The following is a description of a gene set: Human Gene Set: GOBP_REGULATION_OF_ENDOPLASMIC_RETICULUM_UNFOLDED_PROTEIN_RESPONSE studied in species Homo sapiens Any process that modulates the frequency, rate or extent of endoplasmic reticulum unfolded protein response., and this is the list of marker genes: PPP1R15B, XBP1, AKT2, COPS5, BAK1, DAB2IP, ATAD3A, AKT1, AGR2, DDRGK1, FICD, ATF6B, ATF6, ERN1, BFAR, TMEM33, HSPA5, PIGBOS1, UFL1, AKT3, CREBRF, PPP1R15A, BBC3, PTPN1, PTPN2, BAX, WFS1, PIK3R1, BOK, DNAJB9, BCL2L11, NCK1, TMBIM6, ABCA7, NCK2, RACK1, MIR199A1